The following is a description of a gene set: studied in species Homo sapiens Human Gene Set: HP_ABSENT_STERNAL_OSSIFICATION Absent sternal ossification Lack of formation of mineralized bony tissue of the sternum., and this is the list of marker genes: ORC6, VAC14 (NCBI Gene Id 55697), FIG4, ORC1, SOX9